The following is a description of a gene set: The process in which a relatively unspecialized endothelial cell acquires specialized features of an arterial endothelial cell, a thin flattened cell that lines the inside surfaces of arteries. species: Homo sapiens Human Gene Set: GOBP_ARTERIAL_ENDOTHELIAL_CELL_DIFFERENTIATION, and this is the list of marker genes: HEY2, HEY1 (hes related family bHLH transcription factor with YRPW motif 1), NOTCH1, TMEM100, DLL1, RBPJ